The following is a description of a gene set: Mouse Gene Set: GOMF_PROTEIN_PHOSPHATIDYLETHANOLAMIDE_DECONJUGATING_ACTIVITY Catalysis of the reaction:-C-terminal L-amino acid-glycyl-phosphatidylethanolamide + H2O =-C-terminal L-amino acid-glycine + a 1,2-diacyl-sn-glycero-3-phosphoethanolamine. An example of this reaction is the removal of ATG8 from membranes to which it is covalently linked to a phosphatidylethanolamid via its terminal glycine residue. species: Mus musculus, and this is the list of marker genes: Atg4a-ps, Atg4a, Atg4b, Atg4c, Atg4d